Given this list of marker genes FDX2, SLC25A13, MCCC2, PDX1, MMAA, MMAB, SDHD, MCCC1, PCK1, HMGCL (NCBI Gene Id 3155), CYP27B1, COX16, SLC16A1, IVD, CA5A, PAX4, ABCC8 (ATP binding cassette subfamily C member 8), TAMM41, LRPPRC, HMGCS2, OXCT1, COX14, LETM1, MMACHC, TANGO2, GCK, CYC1, CPT1A, GCDH, MCEE, ACAT1, SLC2A2, INS, GYS2, SUGCT, KCNJ11, STAT3, here is a description of the gene set: species: Homo sapiens Human Gene Set: HP_KETONURIA Ketonuria High levels of ketone bodies (acetoacetic acid, beta-hydroxybutyric acid, and acetone) in the urine. Ketone bodies are insignificant in the blood and urine of normal individuals in the postprandial or overnight-fasted state.